Given this list of marker genes HIPK1, PAX2, TFAP2A, CITED2, FOXF2, TH, KDM2B, SP3, TBX2, ALDH1A3, HIPK2, BMP7, FZD5, ZEB1, SIX3, TWIST1, PAX6, WNT16, FRS2, SOX11, CRYAA, WNT5A, PHACTR4, IHH, PROX1, STRA6, IFT172, here is a description of the gene set: species: Homo sapiens The process in which the anatomical structures of the eye are generated and organized during embryonic development. Human Gene Set: GOBP_EMBRYONIC_CAMERA_TYPE_EYE_MORPHOGENESIS